The following is a description of a gene set: from publication Yevshin I, Sharipov R, Kolmykov S, Kondrakhin Y, Kolpakov F (PMID 30445619) Mouse Gene Set: LYL1_TARGET_GENES studied in species Mus musculus Genes containing one or more binding sites for (Lyl1) in their promoter regions (TSS -1000,+100 bp) as identified by GTRD version 20.06 ChIP-seq harmonization., and this is the list of marker genes: Gne, Mapkap1, Gm11690, Hspb9 (NCBI Gene Id 75482), Isca1, 0610030E20Rik, Slc39a13, Gm24553, 2810004N23Rik, Gm20111, Arhgap4, Inpp4b, Ankrd22, Vgll4, Prkag1, P2ry6, Orm3, Clec12a, Spns2, Kif7, Gm2093, Rhobtb1, Laptm5, Gm16433, Lhfpl2, Exoc3, Vps8, Bfsp2, Tec, Rlf, Mettl14 (methyltransferase 14, N6-adenosine-methyltransferase subunit), Gm12976, Gm7363, Ndufs3, Man1b1, Capn3, Nlrp1b, Anapc13, Guf1, Dtnb, Unkl, Egr1, Arl10 (ADP-ribosylation factor-like 10), Psma6, Stat4, Cd200r4, Ppp1r7, Ndufb6, Snord11 (small nucleolar RNA, C/D box 11), Rheb, A930003A15Rik, Dusp2, Gm16876, Gm20069, 2310075C17Rik, Gm15407, Lyrm1, Rai1, Mrm3, Napsa, Ezr, Vars1, Mogat1, Ccnd3, Gm14214 (NCBI Gene Id 435692), Acss1, Snx25, Gm16531, Neil1, Cyp2d22, Nwd1, Cblc, Arhgef10l, Ddx19b, Gm5533, Snapc5 (NCBI Gene Id 67032), Timm17a, Ublcp1, Selplg, Odr4, St6gal1, 1810044D09Rik, Siglece (sialic acid binding Ig-like lectin E), Srsf9, Gm19590, Terf2, Cracr2a, Ubfd1, Arhgdib, Tnni2, Vpreb1b, Rnpep, Aimp1, Gm24610, Nudt1, Map4k2, 6530402F18Rik, Mir7093, B4galnt4, Nrip1, 4930555A03Rik, Hspd1, Brd7, Arrb1, Mrgpra9, Tbkbp1 (NCBI Gene Id 73174), Gmfg, Hcls1, B9d2, Mir3092, Cln8, Milr1, Gdap2, Gm12576, Adcy7, Gm13842, Arpp21, Rtf2, 4930532G15Rik, Rgs18, 5830418P13Rik, Gm16104, Chaserr, Xirp1, Fntb, Fam107b, Mcpt8, Dnajc1, Fam222b, 5830432E09Rik, Sema4b, Ptpn12, Abce1, Echdc3, Ptgs1, Mlycd, Ncf4, Lgals1, Trdmt1, 1700010B13Rik, Sh2d3c, Wsb2, Prkar1b, Sh2d1b1, Ppfibp2, Crot, Gimap1, Dennd1b, Tbce, Ipo11, Bend7, Ccdc86, Gm12967, Endou, Zbtb17, Rabgef1, Cmklr1, Shank1, Heyl, Kif3a, Zer1, Zfp385c, Setd4, Samsn1, Mul1, Megf11, Prss16, Bcl3, Gm14453, Jaml, Pglyrp2, Cdca5, Hspe1, Rsad2, Rab21, Ess2, Selenoo, Odad1, Arhgef2 (NCBI Gene Id 99482), Dcaf1, Nup214, Hmgxb3, Hoxb4, Gm12958, Pecam1, Ccm2, A430034D21Rik, Sde2, Eif4e3 (eukaryotic translation initiation factor 4E member 3), Nrg1, Smarca2, Icam2, 4631405J19Rik, Slx4, Rab23 (NCBI Gene Id 98704), Tln1, Mrpl14 (mitochondrial ribosomal protein L14), Cmah, Ccl9, Vhl, Psmb2, Ighv8-10, Ppie, Aup1, Nek9, Fbxw2, Ube2e2 (NCBI Gene Id 218793), Desi2, Ears2, Tns1, Rad17, Kxd1, Gm19261 (NCBI Gene Id 100502579), Glud1, Ubxn11, Mir7075, Rabepk, Vps37b, Plekhg5, Ap2m1, Arfgef2, Trbv31, Frs3, Cnrip1, Ripor1, Inf2, Mfng, Slc25a20, Tcf3, Aoc1, Scarb2 (NCBI Gene Id 320957), Ralgds, Ulk3, Adss1, Spef2, Tpi1, Ptpn7, Strn4, Slitrk2, Cox18, Gm25846, Ccdc191, Atp6v1b2, Gm19774 (predicted gene, 19774), Luzp1, 5430405H02Rik, Aplnr, Skic8, Nipa2, Gm1604a, Cdk11b, 2610037D02Rik, Cd300c, Med7, Gsn, Ap2b1, Tbc1d8, Serpinb11, Pgap3, Mau2, Traf3ip2, Btnl9, Lman1, Taf1a (TATA-box binding protein associated factor, RNA polymerase I, A), Gcnt1, Trim16, Inca1, Gm16578, Gm10699, Mapkapk3, Hacd4, Fbxw4, Spmip2, Lsm6, Adar, Rbpms, Rpl6l, Kcne3, A630091E08Rik, Runx3, Map2k6, Aqp9, Aoah, Creb3, Cby1, Secisbp2, Rabep2, Ell3, Gm11840, Tnfsf14, S100a3, Cfap97d1, Cdc123, Pi4kb, Ctla2b, Dnajb6, Ss18l2, Cd244a, Hmgb3-ps, Lrrfip1, Rpl9, Bbc3, Tpp2, Ly6g5b, Fbxl13, Smu1, Tpr, Morf4l1, Ogfrl1, Top3a, Gnpda1, 2210022D18Rik, Mapk14, Cdcp2, Glod4, Rassf2, Rc3h1, Tdp2, Gm15473, Micall2, Gm14052, Nfx1, Zfp661, Iscu, Gm23723, 9930012K11Rik, Gm19412, Smim14, Relch, Mrps28, Adamts10, Zfp623, Smim3 (small integral membrane protein 3), Gna15, Atp2b4, Btla, Epg5, Myadml2, Rapsn, Mad1l1, Fam117a, B3galt5, Togaram2, Cyb561, Znhit6, Wipf1, Arhgap30, Tnfsfm13 (tumor necrosis factor (ligand) superfamily, membrane-bound member 13), Ctsg, Rac2, Nol4l, Gm10073, St6galnac6, Zbtb5, Pafah2, Pigv, Kpnb1, Zbtb2, Wnt6, Mbip, Ctla2a, Kif1c, Pamr1, Eml6, Rgs14, Trpm2, 3110031N09Rik, Trap1, Slc17a9, St7, Cd93 (CD93 antigen), Spen, Uchl5, Egfl7, Gm12990, Plaur, Haus3, Card6, Cd300lf, Ppcs, Lrrc74b, Nlrp1c-ps, Gm12271, Arap3, Gan, Lmbrd1, Ctse, Zp1, Noc4l, Cd1d1, Gm15503 (predicted gene 15503), Pced1a, Tdg-ps2, 1810013D15Rik, Gm16252, D030040B21Rik, Zfp207, Gm1972 (NCBI Gene Id 100038830), Gm16023, Rcan1, Or2v2, Pask, Erich1, 3830408C21Rik, Zkscan17, Haus5, Atp8b4, Trf, Gm15523, Dhrs13, Ttbk1, Pf4, Rnase6, Tbc1d9b, Bloc1s5, Cdadc1, Mia2, Slc45a4, Mia3, Polr3f, Rasgef1a, Gm20045, Ginm1, Traf3ip3, Emc3, Gm9951, Aim2, Nfkb1, Gm15326, Baz2a, Recql5, Clec2d, Mmd, Tnfrsf14, Gm14902, Zfp54, Igkv15-101-1, Fgd2, Popdc2, Ncoa4, Gm26766, Rrm1, Fdxr, Galnt9, Mrpl52, Rin3, Armc10, H4c11, Gm16759, Ago1, Ppargc1a, Nlrp3, Mecr, Palld, Erlec1 (NCBI Gene Id 66753), Prmt5, Slc11a1, Ccdc181, Tfap4, Magoh, Nckap5, Dip2b, Cnot1, Slc37a3, Thumpd1, Gm33280, Nlrp1a, Igkv1-108, Prkcz, Gm13483, Snrpc, Eya1, Cd200r1, Aox1, Gm2214, Ppp2r2d, Tmem229b, Polr2g, Gm16938, Coq10b, Gp5, Dusp6, Zdhhc19 (NCBI Gene Id 385631), Nop58, Tspan32, Tle2, Zbp1, Pheta1, Msh6, Gse1, Nipsnap3a, 2010013B24Rik (NCBI Gene Id 72079), F10, 5730460C07Rik, Synj2, Rab8a, Galntl5, Dnajb5, Hoxa7, Tle3, Zfp426 (NCBI Gene Id 72998), Lrig2, Rps10, Gm34648, Gm11683, Slc26a11, Eri2, Blvrb, Akt2, Ebi3, Arhgef37, Stard10, Aqr, Gp9, B230217O12Rik, Cdc42bpa, Aco2, Pik3ap1, Mrtfa, Sidt2, Gm4221, Pex12, Dnai1, Cd53, Klrb1c, Gm10371, Smcr8, Plekha4, AY512931, Pkp3, Nsmaf (neutral sphingomyelinase (N-SMase) activation associated factor), Tmem132b, A530041M06Rik, Dab2ip, Wapl, Tmem214, Gm25897, Unc13a, Sla2, Ndufb3, Zfp953, Tbp, 2310044K18Rik, Gm15518, Csf2rb2, Ugt1a7c, Fermt3 (NCBI Gene Id 98150), Calr, Abi3, Ift52, Snx29, Asic4, Cmtm8, Il18rap, Pfn1, Gbp11, A430108G06Rik, Slc34a3, Gm13919, Coa5, Dusp23, Socs4 (NCBI Gene Id 67296), Kri1, Gm12708, Spata2, Rnf24, Gm19331, Adgre4, Evi5, Nktr, Med6, Tgfbr3, Gpr141, Chpf, Tsr2, Itm2b, Erg, Adgrg1, Nedd9, Sqor, Gm14167, Sart3, Sec24a, Atp1b1, Eloc, Gm24524, Mttp, Smtn, Rps6ka1, Ddx54, Capza2, Pygl, Stam, Arhgap22, M6pr, Mir1249, Lmbr1, Creld1, Zfp597, Gm10392, Tjp3, Patz1, Tent5a, Ankle2, AW554918, Atp13a2, Dzank1, C3ar1, Ablim1, Emid1, Wdr45b, Kdm1a, Gm37885, Myl4, Nlrx1, Tsn, Zfp622, Avpi1, Bub1b, Msh5, Magohb, Bank1, Wdr75, Cep63, Ift140, Ccdc97, Sardh (sarcosine dehydrogenase), Lss, Ntpcr, Fndc11 (NCBI Gene Id 71866), Erich6, Disp2, Gm23897 (NCBI Gene Id 115489853), Aatk, Cbfa2t2, Slc38a6, Ucp2, Sema4a, Gm13386, Tmem30a, Cul3, Serpinb3a (NCBI Gene Id 20248), Tnfrsf9, Cd300c2, 1700125G22Rik, Klf13, Depdc1b, Rpgrip1, Col23a1, Aurkaip1, Gm24867, 4930580E04Rik, Unc93b1, Sgsm1, Runx1, Esyt2, Cd40, Slc15a3, Chst11, Dnm1, Atg16l1, Iqsec1, Ppfia1, Lax1, Lgals2, Rnf139, Mir3074-2, Nckap1, Mapk6, Prkacb (NCBI Gene Id 18749), Bmx, Abcf2, Rpl36-ps9, Rassf4, Tmem184c, Dmpk, Slc35f5, Clasp2, Slc35c2, Ticam2, Rhoh, Ppp1r18, Slk, Lratd2, Rabl2, Pkib, Zwint, Trpv2, Mpo, Glis2, Tmem150b, Tnfrsf13c, Asic3, Zbed4, Wdhd1, 1600010M07Rik, Gm7492, Angpt1, Gm13199, Slc29a1, 4933431K23Rik, Gm12472, Dnaja1, Gm10655, Smim12, Wnt3, Camk2b, Tysnd1, Bltp1, Tdrd9, 1700055D18Rik, Acox3, Def6, Ifitm7, Ash2l, Rnf166, Cd28, Dxo, Tbcel, Scn1b, Irf5, Ptafr, Taf9, Cdk1 (cyclin dependent kinase 1), Atp6v1g2, Mir7031, Or2at4, Ndufa10, Slc38a10, Arap1, Msh3 (NCBI Gene Id 17686), Usp22, Phactr4, Gm17435, Cd300lb, Trub1, Gm19557, Pla2g5, Brms1, Gm16084, Ddc, Tbl3, Gm24917, Pinx1, Styk1, Misfa, Dnajc10, F730311O21Rik (RIKEN cDNA F730311O21 gene), Prr14, Gm14487, Ppil4, Fgr, Zfp141, Tm7sf2, Cstf2, Pkd1l2, Gm15564, Nucb1, Anks1, Nfe2, 6030443J06Rik, Mbd6, Tanc1, Galnt7, Gm12069, Zfp1, Csf2rb, Gm26287, Calm4, Bace1, Pld4, Slc28a2, Cass4, Clec4a2, Ncf2, 2310010J17Rik, Ttc39b, Ankdd1b, Rag1, Slc25a29, Gm37125 (predicted gene, 37125), Eef2k, Arhgap24, Smad4, Mir7013, Plscr2, C030034L19Rik, Ceacam2, Arl6ip1, Nlrc3, Dus2, Crtc3, Foxred2, Relt, Lsm5, Shb, Ak1, Tal1, Gm26513 (NCBI Gene Id 108168225), Med27, Igf1, 2310009B15Rik, Wdr5, Chid1, Capns1, Dusp3, Otud3, Pdlim2, Xrcc2, Tpd52, Gpam, Bche, Nras (NCBI Gene Id 99853), Il16, Surf6, Rnf227 (NCBI Gene Id 80515), Hsd17b14, Zng1, Rasal1, Dclre1c, Rnf38 (NCBI Gene Id 73469), Itgb2, Sipa1l3, Eya2, Impdh2, Gm14455, Scand1, Fcho1 (NCBI Gene Id 97488, FCH domain only 1), Gm14901, Ptger4, Tnk2, Txlnb, Mapkapk5, Ttll5, Card9, Alg8, Crisp3, Rap2c, Snx15, Acsf2 (acyl-CoA synthetase family member 2), Cbfa2t3, Gm13655, Gm10044, Stab1, Cd33, Tef, Ercc2, Gm25623, Igf2r, Hhex, Gnas, Ube4a, Faf1, Fbp2, Rptor, Tle6, Atp8a2, Pphln1, T2, Prkcb, Gm568, AB124611, Tom1l2, Thoc3 (NCBI Gene Id 73666), Zfp69, 3110082I17Rik (RIKEN cDNA 3110082I17 gene), Rbp2, Sh2b2, Gm5393, Smim35, Arhgap25, Cenpk, Gm4219, Itgb5, Epb41l4b, Tinagl1, Anapc10, Cox16, n-R5s41, Ace, Mtus1, D130020L05Rik, Dip2a, Gm28809 (NCBI Gene Id 115490433), Mirt1, Gm23220, I830077J02Rik, Lat2, Mir24-2, Dscam (DS cell adhesion molecule), B130024G19Rik, Rce1, Nsmce2, Arhgef3, Fahd2a, Tmem147os, Fam110a, Ms4a6b, Phlpp1, Cyp11a1, Itgal, Cd69, Usp19, Ilk (integrin linked kinase), Ddx49, Pla2g6, Ms4a3, 8030442B05Rik, Nck2, Cdk9, Map3k8, Smim6, Tmem219, Lat, Lonp2, Stk19, Inhba, Mapre2, Zhx3, Acad9, Serpinf1, Megf9, Nat10, Cfc1 (NCBI Gene Id 98634), Poln, Fech, Rab43, F2rl3, Trim28, Epn1, Gm12418, Ttc34, Dock8, Sspo (SCO-spondin), Eprs1, Dnah1, 4930455G09Rik, Rmdn3, Tubgcp6, Ppig, Lsmem1, Brd10, Zeb2os, Ifrd2, Ttc9, Niban3, Gm12092, Slc25a16, Sh3kbp1, Bdp1, Sfr1 (NCBI Gene Id 67788), Glis3, Zmiz1, Thap6, Pelp1, Ttf1 (NCBI Gene Id 99278), Inpp1 (NCBI Gene Id 98626), Ovca2, F830115B05Rik, Sec14l2, Clic1, Mapkapk2, Gm16120, Aox4, Abitram, Hnrnpf, Tmem131l, 1110002L01Rik, Tatdn2, Plvap, Slc35a1, Slc18a1 (NCBI Gene Id 352946), Dennd4b, Ambra1, Cops3, 1700073E17Rik, AI467606, H2-DMb2, Slc31a2, Htra2, Gm11738, Senp2, Spty2d1, Ptprv, Mir223hg, Mir199b, Mir3154, Oxr1, Gm5111, Gm27252, Alkbh8, Tlnrd1, Ighv14-2, Hmga1 (high mobility group AT-hook 1), Nolc1, Rcbtb2, Elmo2, Mfn2, Ccdc14, Tanc2, Tmem198, Ppp5c, Rassf5, Shisa4, Mrgpra6, Sap30bp, Slc26a9, Rcn1, Gm7166, Grn, Gm16416, Gm6030, Cmtm7, Exd2, Atp6v0a2 (NCBI Gene Id 97206), Atp1a3, Gm7891, P2rx1, 4930429F24Rik, Lias, Lcn9, Taok3, Wdsub1, Ptges, Ppy, F2r, Gm14062, Cast, Gm11729, Agpat3, Paip2, Ptpn11, Elp1, Cfap96, Sla, Pacsin2, Adamtsl2, Spmip4, Gypc (NCBI Gene Id 71683), Mov10, Sorbs1, Prkab1, Hbb-bh2, Dhrs11, Ppp2r5a, Polm, Jrkl, Slc16a14, Zfp568, 4632411P08Rik, Slc23a2, Myl9 (NCBI Gene Id 98932), Slc7a1, Gm12301, Nfkbil1, Cilk1, Osbpl6, Ddx19a, Prx, Sh3bp2, Clnk, Hm629797, Igkv1-135 (NCBI Gene Id 243420), Rgsl1, Dtwd1, Pik3cd, Tax1bp1, Gm18981, Pgls, Dmwd, Pcid2, Nat8f1, Slfn14, Otud6b, Iqgap2, Foxm1, C030013C21Rik (NCBI Gene Id 77417), 4930513N10Rik, Phkg2, Hmgxb4, Gngt2, Lair1, Gm13022, Ccny, 0610040B10Rik, Gm19705, Kansl1l, Tusc1, Usp53, Prss57, Dgkz, Ugt1a6a (UDP glucuronosyltransferase 1 family, polypeptide A6A), Mir7048 (microRNA 7048), Cct4, Prkd2, Rexo5, Mmp8, Fam53c, Oacyl, Mbd3, Bcr, Senp5, Cenpa, 5730480H06Rik, Nccrp1, Gm37120, Apoc2, Nt5dc3, Ppm1f (NCBI Gene Id 71214), Tagap, 4933406C10Rik, Slc35c1, Myo1g, Klhl35 (kelch-like 35), Fosl1, Adgrg5, Dennd4a, Rbm42, Abcc1, Bnc2, Plaa, Tph2, Dhx58, Sugp1 (SURP and G patch domain containing 1), Srpra, Pik3ip1, Ubr4, Tmem144, Cmpk2 (NCBI Gene Id 80594), Stn1, Fcrl1, Cxxc5, Gm11420, Limk1, Cysltr2 (cysteinyl leukotriene receptor 2), Klrd1, Robo3, Hip1r, Mrpl2, Cx3cr1, Cnbd2, Tarm1, Mir202, Prkrip1, Cntn2, Akt1, Slc35e1, Gm9408, Hes6, Mir27a, Vps72, Tmem86b, Tespa1, Lrrc32, Mrpl15, Fam131a, Sbno2, Slc2a6, Rgs10, Hk1, Mir1950, Cd300ld3, Sema4d, Gm11346, Atxn7l1 (NCBI Gene Id 72174), Asb3, Tfr2, Traf1, Spo11, Pomp, 4930502E09Rik, Ctdspl, Gm14866, Il6ra, Maml1, Smad3, Senp1, Akap13, Arhgap18, Gm9964, Anxa1, Katnip, Tnfsf8, Klhl6, Il6, Ifngr2, Lyve1, Gm33994, Cyth4, Col15a1, Timm44, Anapc2, Serpinb12, Rag2, Hycc1, Acot1, Slc6a12, Ncor2, Tlr5, Hk1os, Fbxo42, Cul4a, Mir5114, A230056P14Rik, Supv3l1, Mgat4b, Usp3, Capn5, Grin2c, Gm17597, Fancd2, Ugt1a6b, Dnttip1, Slc36a1os, Mir6406, Gm5148, Fam32a, Cnr2, Adamts4, Gm12542, Gm807, Eno1, Pla2r1, Wfdc3, Uba7, Emc7, S100a4, Kdm8, Ntng2, Tbck, Gm13920, Arid3b (NCBI Gene Id 56380), Ccdc12, Dapp1 (dual adaptor for phosphotyrosine and 3-phosphoinositides 1), Wbp2, Ifi47, Gtpbp10, Dgkd, Ak6, Mir6367, Pik3cg, Nup153, Nat14, Zfp683, Actl6b, Evi2b, P2ry14, Asb2, Ptprj, Klra5, Ahcyl1, Mroh8, Cd22, Spns3, Gm15423, Sumf1, Pole, A3galt2, Abhd12, Zeb2, Tmem39a, Aurka, Mir3075 (microRNA 3075), Ppp1r16b, Ubox5, Gm6057, Cd5, Gm16225, Furin, Dnase1l3, Unc13d, Mrps36-ps2, BE692007, Tmem119, Nup133, Tnfsf13b, Rapgef3, St6galnac3 (NCBI Gene Id 20447), Gm11769, Rchy1, 4833422C13Rik, Phf3, Mir23a, 9130019P16Rik, 4933433G15Rik, Gpr12, Gtf2h3, Slc66a3, Fkbp1a, Dimt1, Sike1, Mir142hg, Rnasek, Nphp1, Sypl1, Psenen-ps, Tyrobp, Itpkb, Calm5, Trbv1, Cenpv, Washc5 (NCBI Gene Id 97946), Gm14210, Tmem147, Napg, Ms4a7, Ifit1bl1, D830026I12Rik, Nbeal2, Pik3r6, Ftdc1, Prr13, Mmgt2 (membrane magnesium transporter 2), Trem1, Gm25939, Cnot6l, BC043934, Dok2, Med9os, Elf2, Hnf1b, Lbp, Amz2 (NCBI Gene Id 13929), Zyx, Cth, Tbc1d1, Tbxas1, Tmem135, Dll1, Il21r, Zmynd10, Ppwd1, Gp1ba, Cfap45, Magt1, Syngr1, Adamts14, Bhlhe41, Tmem123, Iffo1, 9430069I07Rik, Unc119, Dgki, Nelfa, Vps4a, Acbd4, Epor, Foxa1, Slc36a3os, Ehd1, Tmem273, Taf3, Casp8ap2, Mir3074-1, Cd300e, Llph, Usp5, Nat8b-ps, Agtpbp1, Cfp, Commd8, Lrrc8b, 2310001H17Rik (NCBI Gene Id 76432), 8430423G03Rik, Wdr74, Rasgrp2, Picalm, Itga4, Btbd17, Depp1, Gm17039, Sapcd1, Irag2, Man2a2, Zcrb1, Sh3bgrl3, Gfi1b, Nfkbie, Il1rl1 (NCBI Gene Id 17082), Havcr2, Ceacam1, S1pr3, Mir7686, Cdc73, Nadk, Smim41, Gm13270, Rimoc1, Cpa3, Prkar1a, Lrrc66, Shld2, Tnfsf12, Synpo, Cfh, Bach2it1, Trmt10a, Orc5, Pop4, Trabd, Bet1 (Bet1 golgi vesicular membrane trafficking protein), Flot1, Scrn1, Chad, Mylk3, Rarg, Acsl3, Cyth1 (NCBI Gene Id 19157), Gm4764, Fam236d, Mrpl1, E130307A14Rik, Ccl3, Mmadhc, Pde4d, Serpinb10, Tlr4, Ptp4a1 (NCBI Gene Id 98792), Ski, Zfp740, Plxnb2, Lst1, Ssna1, 4930456G14Rik, Tac4, Trmt61b, Mcph1, Clptm1l, Cibar2, Khdrbs2, Ndufa4, Cd82, Rrp1b, Scimp, Itga8, Gm13093, P2rx3, Dhrs3, Zfpl1, 6820402A03Rik, Cul7, Sucnr1, 1810010H24Rik, 6030468B19Rik, Cd200r3, Spsb4, Wincr1, Qtrt2, Hpn, Phactr1, Mrm2, Gm25921, Eif4ebp1, 1700054O19Rik, Rasgrp3, Tbrg4, Iftap, Cdk2ap1, Ddx51, Smpd1, Pabir1 (NCBI Gene Id 73676), Zdhhc4, 1700020M21Rik, Mgat1, 1700001K19Rik, Spem2, Prrt1, Trmt61a, Rffl (NCBI Gene Id 75134), Appl2, Fam227a, Arnt, Csf1r, Nup155, Tfrc, Lonp1, Spp1, Glipr1, Fut7, Cox19, Elovl5, Ppp4r1, Nek6, Ost4, Gpatch3, Bnip3l, Endov, Tcirg1, Gm15477, Mesd, Adam28, Fbxl18, Gm23451, Spta1, Erlin2, Usf1, S100a2, Ighv11-2, Asxl2, Capn7, Itga2b, Abhd1, Fastkd5, Nfam1, Vwa3b (NCBI Gene Id 70853), Gm16341, Fli1, Lig1, B3galt2, Myo1f, Tgfbrap1, Il1r1, Dock10, Ndel1, Xrcc6, Mbnl1, Coro1a, Atosb, Tha1, Hemgn, Gm26740, Dnaaf5, Steap3, Mxd4, Atp13a3, Igll1, Rimklb, Pcbd1, Foxred1, Exosc4, Ctu2, Gm20655, Fbxo31, Cyp4f18, Naip2, Dazap1, Fancc, Spi1, E2f8, Fry, Plekha7, Phf5a, Ccdc124, Pstpip1, Cope, Eef1g, Hspbap1, Dok3, Ppdpf, Rasa4, Slc41a3, F13a1, Fam124b, Atat1, Duoxa1, Zdhhc18, Jak1, Neurl3, Dglucy, Rrp1, Ddx27, Stau1, Dek, Atp6v0a1, Prkag2, Tfeb, Ttc13 (NCBI Gene Id 260381), Pttg1ip, Mei4, Gm15581 (NCBI Gene Id 102631779), Dnajb12, Tmem207, Fam151b, Fcgr1, Calcrl, Zfp175, Map7d2, Gm13391, Fcgr3, Ggt5, Tnni1, Paqr7, E530011L22Rik, Tomm6, Slc49a3, Fosl2 (NCBI Gene Id 14284), Treml2, Scfd2, Gm1976, Cdv3, Ndufs6, Angpt4, Gm27011, Eif2b1, Dhrs9, Chchd5, Bmf, Gm29243, Med9, Ccdc9b, Ubr1, Zfp652, Zmynd12, AI597479, Zfp787, Trmt5, Odf2l, Lhx3, Nrg4, Csf3r, Crlf3, Stag1, Mef2c, Csrp1, Msantd2, Kpna1, Hint3, Reps1, Sned1, Mapk1ip1, Gpr55, Esam, Papln, Ccdc88b, Hes1, Smndc1, Ier3, Pira12, Sppl2c, B430010I23Rik, Rps6kb2, Unc50 (unc-50 homolog), Asap1, Vsir, Exoc3l, Tnip3, Naa30, Gpr84 (NCBI Gene Id 80910), Zfand2a, 1700060C20Rik, Gm11433, Pla2g15, 5031425F14Rik, Ube2o, Sgms1, Erg28, Cwc25, Hmgcll1, Atp1b3